Given this list of marker genes Ahcyl1, Cftr, Aqp1, Slc5a1, Aqp4, Mip, Inpp5k, Large1, Ext2, Aqp6, Aqp7, Ext1, Slc14a1, Itpr1, Ednrb, Aqp3, Upk3a, Mllt6, Slc4a11, Cldn18, Sctr, Pkp1, Slc26a6, Aqp5, Pdpn, Mylk2, Aqp9, Aqp8, Aqp11, Hyal2, Aqp2, Has2, Csf2, Ctns (NCBI Gene Id 83429, cystinosis, nephropathic), Scnn1b, Edn1, here is a description of the gene set: The directed movement of substances that are in liquid form in normal living conditions into, out of or within a cell, or between cells, by means of some agent such as a transporter or pore. studied in species Mus musculus Mouse Gene Set: GOBP_FLUID_TRANSPORT